The following is a description of a gene set: studied in species Homo sapiens Human Gene Set: GOMF_5_DEOXYRIBOSE_5_PHOSPHATE_LYASE_ACTIVITY Catalysis of the reaction: a 5'-end 2'-deoxyribose-2'-deoxyribonucleotide-DNA = (2E,4S)-4-hydroxypenten-2-al-5-phosphate + a 5'-end 5'-phospho-2'-deoxyribonucleoside-DNA + H+., and this is the list of marker genes: HMGA1, POLB, POLG, HMGA2, XRCC5, XRCC6, POLQ, POLL